Given this list of marker genes ARSI, ME3, GDI2, CERCAM, OSBPL5, VAV1, GAS8, ADCK1, ACACA, DEPP1, TLE6, TGFB2, MCOLN1, PHTF1, ZNF675, CRTAC1, MIR3922 (microRNA 3922), RNU6-85P, PIANP, AURKB, HEBP2, FAM86MP, KCNN1, ATP9B, ITGA7 (NCBI Gene Id 81988), SLC39A3, FCHO1, KCTD21-AS1, GRM4, RYR3 (NCBI Gene Id 6263), CWC25, CST1, WDR81, WNT8A, ADAMTS7P5, EIF4E1B, CCN5, TBC1D3P7, WAKMAR2, TUBA1B-AS1, MED16, TNFRSF12A, CRY1, LYSETP1, MIR3162, TECR, SSX7, C6orf141 (NCBI Gene Id 135398), TMCO6, ENSG00000265246, SLC6A1, BBLNP1 (NCBI Gene Id 133039961), RPS19BP1, PNCK, MTO1, DDHD2, GBA1, POLR3K, IMPDH1P6, RPL32P27, TTLL13, BMP8B, PORCN, BLOC1S1, ITGB5, TBX6, PDE6G, MFSD2B, CMKLR2-AS, TUBA1B, PTPN3, SPATA20, ZNF548, ANO8, PSMD8, SMG7, RBPJ, CPLX2, AGMAT, ACER3, NCOR2, CDK4, LINC02833, PIP5KL1, CUL4AP1, LINC01505, TTC1, H1-10, THA1P, PTPN5, TGFB2-AS1, RARA, PIK3R5, ZSCAN30, ARMC8, ITFG2-AS1 (NCBI Gene Id 647957), UBXN4, ISOC2 (NCBI Gene Id 79763), JAZF1-AS1, RIN3, NTSR1, ARPC5L, CACYBP, CARD14, DTX1, HIF3A (hypoxia inducible factor 3 subunit alpha), ENSG00000187951, BRF1, TMEM147-AS1, ANKRD18DP, SERINC2, PDCD7 (programmed cell death 7), NEURL4, ADAR, SYNPO, TTC5, SH2D3C, ADA, LINC00917, LAMP1, ANGEL1, LINC01641, NMUR2, MIIP, CCDC120, IL17RD, MB, SF3A3, RN7SL93P, MIR381, BRPF1, EXOSC2, COQ10A, SMG7-AS1, LTBP4, SDC4, LRRCC1, CC2D1A (NCBI Gene Id 54862), NLE1, ILDR1, RAI1, CCDC57, STOML3 (NCBI Gene Id 161003), DNAI4, UBE2V1, FTSJ1, CCNL2, SNHG30, SPATS2L, FMN2, RNU6-612P, PXMP4, STX6, H4C8, DHRS13, POMT2, MYH11, AOX1, PPP1R9B, TRIM7-AS1, CDCA7P1, LINC01485, MIR3611, WAPL-DT, ABHD17A, LINC01132, NIBAN2, TMEM98, CTIF, IL2RB, SFSWAP, DUS2, LINC01574, RNU6-339P, TWF2, SNRNP25, GTPBP3, SF3B2, BTN2A1, SRMS, VPS39, CCDC40, SCN1B, CIMAP1D, KCNK1, KANK3, RN7SL836P, SYCE2, CDC42EP4, CFAP299, L1TD1, MIR9-1HG, LDLRAD2, IL16, LIM2-AS1, MRPL4 (NCBI Gene Id 65006), EYA2, MAP7D1, CXXC1, FABP5P3, ABTB1, REPIN1, LINC02557, DAGLB, WDR55, CLDN23, DRG2, EVA1C, B4GALT5, MRPL39, NOL6, RNU6-1003P, RNU6-166P, VWCE, MIR6729, RN7SL546P, TRMO, METTL3, NFIC, RNU6-466P, CEACAM16-AS1, ARPC1A, ZNF790, MARK4, ADAP1, ORC5, ASS1P5, COPS5P1, DDX17, SCN3B, ALDH7A1, MAP4K5, TGFB1, CCDC162P, SLC22A11, MRPS18A, ANAPC2, BPIFB3, ZCCHC4, EFNA2, RBBP5, SCN4B, KLHDC9, CLIP3, RTN2, KRT18P45, RNU6-847P, LONP1, RORA, GALNTL5, EML2, CCNI, CERS1, MRPS21P7, DMAP1, VPS37B, UNC13D, GGT1, ZNF302, PRR14L, EDDM13, MED21, GGTLC1, KSR1, ABCB9, B4GALNT1, SREBF1, CFAP92, RRN3P1, RNU6-1340P, RNA5SP474, ERGIC1, SEMA4B, ENSG00000244137, ZDHHC18, SUSD3, NDUFS7, KAT8, SH2B3, CEACAM21, ITGA5, CDK5RAP2, STAT6, SLC15A3, PDE4A, HNF1A-AS1, SHANK1, UBE2H, PPFIA4, CAGE1, NAPSA, CSF3R, POLR2D, MIR3529, ENSG00000269172, RPL38, MIR9-1, PNPLA6, GTF2I, S1PR5, TPM4P1, GIT2, IL12RB1, SLX4, PLA2G4C, RN7SL454P, RNF167, DYRK1A, MYO19 (myosin XIX), RPS21P7, DPYSL2, MIX23, CARMN, VGLL3 (NCBI Gene Id 51159), PMM1, RASA4EP, LPIN1, LINC02868 (NCBI Gene Id 388667), IGSF21, CLK3, CYP1B1-AS1, DPP9, TRIM37, CD160, FUT6, MAP3K14-AS1, NUCB1-AS1, TFAP2A-AS1, COPS3, ITFG2, BRWD1, TFEB, MYOM3, DHTKD1, CRISPLD2 (NCBI Gene Id 83716), MIR487B, HID1, PTPN2, PNKP, ATOSA, ARMH3, LINGO1, GXYLT2, LINC01235, FES, BTF3, TCEAL8P1, RFC3, RFC1, LUZP1, SDAD1P3, C1orf87, SLC25A21, PSMG3-AS1, C3, IL4R, TRAV15, CARHSP1, CARD11, SLA, RASGEF1B, DHX37, FLACC1, TLR9, CAMK1, FAM86EP, SLC1A2-AS2, TRIM15, BTN2A2, CROCCP3, RNU1-101P, SNRPA, NT5DC3, CACNA1A, ALDOA, SYNDIG1L, CCDC65, GGTLC4P, P4HTM, NCKAP1L, NANOGNB, FRMD7, SLFN12, COL4A6, LYPLA2P1, MFSD12, TLE5, UBAC2-AS1, CARD10 (NCBI Gene Id 29775), ITGAL-AS1, PSME1, SLC4A5, AKAP9, AP1S3, CRADD, SNCB, DOCK6, MYRF-AS1, RHOH, MIR4734, ABCB1, RPL15P22, UTP4, OR1X5P, PLEKHG2, NGEF, UBE2H-DT, FAM222A, RNF227, DCP1A, SUGT1P4, SPMIP10, MIR4425, TRIM55, RNU4-62P, POFUT1, TRAPPC3, ENSG00000272008, RN7SL33P, ENSG00000260592 (novel transcript, antisense to TMC5), PLA2G15, H4C5, SUSD6, HNRNPMP2 (heterogeneous nuclear ribonucleoprotein M pseudogene 2), RPS26, ANGPTL6, APC2, ESPN, RND1, RB1CC1, CCNP, ITGB3BP, CCDC33, TESC, COL1A1, BORCS8, TOR1A, KMT2B, USP30, TYK2, QSER1, ARID1B, FCHO2, HAPLN2, SBSN, BORCS6, DNM1L, RPL36, PAXBP1, MTFMT, TMC6, COLGALT1, MRPL38, MTND1P14, STX4, PPIAP21, TCAP, EPCIP-AS1 (NCBI Gene Id 54067), LINC00431, RAD23A, SAXO5, ZNRF4, ZNF271P, MTF2, RPS29P7, RNU6-386P, RAB1A, LIPA, NRTN, EFCAB7, MLST8, GLG1, TNFRSF10B, PPP2R2A, TNRC18, TONSL, FLII, SLC36A3, LINC00963, MFNG, GLRX5P2, CFAP144, here is a description of the gene set: studied in species Homo sapiens Human Gene Set: ZNF623_TARGET_GENES from publication Yevshin I, Sharipov R, Kolmykov S, Kondrakhin Y, Kolpakov F (PMID 30445619) Genes containing one or more binding sites for (ZNF623) in their promoter regions (TSS -1000,+100 bp) as identified by GTRD version 20.06 ChIP-seq harmonization.